The following is a description of a gene set: part of: Signaling by Activin Reactome Pathway: Antagonism of Activin by Follistatin electronically inferred by orthology from the curated human pathway This event has been computationally inferred from an event that has been demonstrated in another species.<p>The inference is based on the homology mapping from PANTHER. Briefly, reactions for which all involved PhysicalEntities (in input, output and catalyst) have a mapped orthologue/paralogue (for complexes at least 75% of components must have a mapping) are inferred to the other species. species: Mus musculus, and this is the list of marker genes: Inhbb, Inhba, Fstl3